The following is a description of a gene set: species: Mus musculus Enables the transfer of substances, sized less than 1000 Da, from one side of a membrane to the other. The transmembrane portions of porins consist exclusively of beta-strands which form a beta-barrel. They are found in the outer membranes of Gram-negative bacteria, mitochondria, plastids and possibly acid-fast Gram-positive bacteria. Mouse Gene Set: GOMF_PORIN_ACTIVITY, and this is the list of marker genes: Bak1, Tomm40l, Vdac1, Tomm40, Vdac3, Vdac2